Given this list of marker genes COL9A2, COL2A1, COL9A3, MATN3, B2M, COL9A1, TRAPPC2, SLC26A2, COMP, here is a description of the gene set: Joint pain affecting the hip. studied in species Homo sapiens Human Gene Set: HP_ARTHRALGIA_OF_THE_HIP Arthralgia of the hip